The following is a description of a gene set: Mouse Gene Set: GOMF_ORNITHINE_DECARBOXYLASE_ACTIVITY Catalysis of the reaction: L-ornithine + H+ = CO2 + putrescine. species: Mus musculus, and this is the list of marker genes: Odc1, Azin2, Ldc1, Azin1, Oaz1, Oaz2, Oaz3